Given this list of marker genes COG6, TMEM115, COG1, COG5, COG3, COG4 (component of oligomeric golgi complex 4), COG8, CDC42 (NCBI Gene Id 998), COG7, COG2, here is a description of the gene set: A multisubunit tethering complex of the CATCHR family (complexes associated with tethering containing helical rods) that has a role in tethering vesicles to the Golgi prior to fusion. Composed of 8 subunits COG1-8. species: Homo sapiens Human Gene Set: GOCC_GOLGI_TRANSPORT_COMPLEX